The following is a description of a gene set: Mouse Gene Set: CUI_CDC2_GM_CSF_RESPONSE_UP Genes positively differentially expressed in cell type: cDC2 (conventional dendritic cell type 2) upon treatment with cytokine: GM-CSF in mouse lymph nodes in vivo. species: Mus musculus from publication Cui A, Huang T, Li S, Ma A, Pérez JL, Sander C, Keskin DB, Wu CJ, Fraenkel E, Hacohen N (PMID 38057668) Cytokines mediate cell-cell communication in the immune system and represent important therapeutic targets. A myriad of studies have highlighted their central role in immune function, yet we lack a global view of the cellular responses of each immune cell type to each cytokine. To address this gap, the authors created the Immune Dictionary, a compendium of single-cell transcriptomic profiles of more than 17 immune cell types in response to each of 86 cytokines (>1,400 cytokine-cell type combinations) in mouse lymph nodes in vivo. A cytokine-centric view of the dictionary revealed that most cytokines induce highly cell-type-specific responses. For example, the inflammatory cytokine interleukin-1β induces distinct gene programmes in almost every cell type. A cell-type-centric view of the dictionary identified more than 66 cytokine-driven cellular polarization states across immune cell types, including previously uncharacterized states such as an interleukin-18-induced polyfunctional natural killer cell state., and this is the list of marker genes: Psmb8, Odc1, Myl6, Twf2, Mcrip1, Stxbp6, Srm, Cycs, Pa2g4, Denr, Hs3st3b1, Eif4g2, Lims1, Hnrnpab, Bcl2a1d, Rara, Socs3, Macroh2a1, Ywhae, Trio, Myadm, Slc2a1, Mthfs, Eif4a1, Eef1e1, Atp5mc3, Klhl18, Dynll1 (NCBI Gene Id 56455), Rrp15, Plet1, Anxa2 (annexin A2), Sfxn1 (sideroflexin 1), Socs2, Mrpl12, Lcp1 (NCBI Gene Id 52646), Ufc1, Batf3, Car2, Ncl, Uck2, Anxa3, Ddx39a, Kmo, Flt1, Slc29a1, Pcgf5, Kdm5c, Hspd1, Rab35, Cct5, Ffar2, Eno1, Vps53, Mdn1, Rrp1b, Srsf3, Sarnp, Ppp1r14a, Ubl4a, Capzb, Bcl2a1b, Xbp1, Actr3, Spint1, Yrdc, Capg, Brix1, Ssb, Uqcr10, Etfb, Adam8, Lyrm2, Ldha, Exosc2, Snrpa1, Rap2a, Sf3a1, Rpf2, Ran, Tcea3, Sf3b3, Sdad1, Gimap1, Gfra2, Hspa8, Fnbp1l, Prpf31, Pdcd1lg2, Ostc, Ptpn7, Srp14, Med28, Pqbp1, Coro2a, Bcl2a1a, Pacsin2, Ralb, Nop16, Ncbp3, Ciita, Hnrnpk, Eif5a, Ppa1, Ddost, Ggct, Gapdh, Sec61g, Rab3il1, Actr2, Psmg3, Srsf7, Psme2, Chchd4, Ass1, Wdr1 (WD repeat domain 1), Cish, Nme1, Hnrnpf, Irf5, Zfp706, Slc27a3, F10, Eif4e, Tomm5, Rwdd1, Serpina3g, Ruvbl1 (RuvB-like AAA ATPase 1), Gspt1, Ms4a6d, Snx3, Rexo2, Srsf2, Dlst, Pdcd5, Cfl1, Ost4, Nop58, Smdt1, Emilin2, Arl8b, Hsp90ab1, Sema4a, Nudt2, Naaa, Tns1 (tensin 1), Pla2g15 (phospholipase A2, group XV), Hspa4, S100a4, Rrp12, Cbfa2t3, Rnf7, AA467197, Fcgrt, Fcgr2b, Elob, Agpat5, Serbp1, Ermp1, Ppp1r14b, Anks3, Phb1, Myo1e, Ndufb4, Psmc3, Cd300lf, Trappc6b, Mybbp1a, Cst3, Srp9, Tnfrsf13b, Tmem19, Tmem65, Samd1, Creb5, Snx2, Anp32e, Pik3r5, Rhot1, Noct, Eif1, Rcc2 (NCBI Gene Id 72534), Qpct, Mrpl20, Ccdc86, Fbl (NCBI Gene Id 14113), Jpt1, Gtpbp4, Rpn2, Scn3a, Eif3j1, Aamp, Ywhah, Ccl17, Traf5, Nus1, Mtmr4, Erh, Timm50, Chchd1, Pfdn2, Ywhaz, Il1rn, Heatr3, Eif4g1, Clec4n, Cdkn1a, Cox7b, Pfdn1, Lta4h (NCBI Gene Id 16993), Txnl4a, Mvp, C1qbp, Vrk1, Map2k3, Hnrnpa3, Lyar, Zfand3, Cyp4f16, Vps36, Cmpk1, Cltc, Id2, Malt1, Llph, Atp5mc1, Mrpl34, Basp1, Plk2 (NCBI Gene Id 20620), Cyb5b (NCBI Gene Id 66427), Rras2, Olfm1, Atp6v0a1, Cox17 (NCBI Gene Id 12856), Hnrnpa2b1, Chd7, Vwa5a, Ndufb6, Matk, Uqcc2, Med8, Ahsa1, Abce1, Apex1 (apurinic/apyrimidinic endonuclease 1), Mrpl54, Zdhhc21, Syncrip, Pdia6, Vasp, Arpc5, Snrpf, Cstb, Spr, Atp5me, Cox6a1, Tpm3, Ywhab, Enah, Ybx1, Wdfy4, Hnrnpll, Aprt, Ppie, Ap2m1, Mphosph10, Socs1, Romo1, St7, Nrp2, Rbx1, Mrps36, Stip1, Chordc1, Dkc1, Lpl, Ndufc1, Mrpl11, Ranbp1, Dok2, Cct8, Pkm, Ctsz, Ank, S100a6, Clec10a, Nsd2, Serp1 (NCBI Gene Id 28146), Nans, Cox8a, Uchl3, Sav1, Emg1, Vdr, Snrpc, Nr4a3, Sdc4, Mrto4, Ptpn1, Plek, Cdc42, Bak1, Cct3, Sh3bgrl, Tbca (NCBI Gene Id 21371), Mmp12, Runx1, Vcp (valosin containing protein), Ece1, Tarm1, Vps29, Scimp, Max, Farsa (phenylalanyl-tRNA synthetase, alpha subunit), Rab14, Magt1, Psmc5, Mdh2, Thumpd3, Timm8b, H1f10, Psmb5, Tcof1, Prkcd, Cd164, Atp6v1e1, Sigmar1, Polr2a, Hsp90aa1, Tet2, Snd1, Reep3 (receptor accessory protein 3), Ndufs4, Bysl, Srsf9, Sf3b6, Atp5pb, Tomm40, Acly, Mrpl36, Pfdn4 (NCBI Gene Id 76717), Pnp, Set, Slfn2, Hspa9, Sipa1l3, Snn, Ezr, Psmb6, Prelid1, Ptges3, Arhgdia, BC031181, Pfn1, Mif, Psmd2, Arhgef40, Fkbp1a, Ubtf, Arpc2, Tuba1b, Rsl1d1, Myl12a, Alyref, Pilra, Ppp2r1a, Gnb4, Mettl1, Septin7, Lfng, Eif1ax, Mtss1, Pgk1, Psma4, Mrps10, Pfkp, Gabarap, Riok3, Hars1, Rrp9 (NCBI Gene Id 27966), Nup88, Nckap1l, Mbd2, Irf4, Bax, Cdh1, Ndufb7, Vim, Dars1, Eps8, Tmem256 (transmembrane protein 256), Fh1, Orai1, Arpc1b, Fabp5